Given this list of marker genes G6PC3, TCN2, SKIC3, SPRED2, PTPRC, FAT4, TPP2, PTEN, RMRP (NCBI Gene Id 6023), ACP5, UHRF1, TERC, TTC7A, TTI2 (TELO2 interacting protein 2), TOM1, CORO1A, RAC2, STING1, LBR, WAS, CD3D, CD81, DEF6, FCHO1, BCL11B, GATA2, TNFAIP3, C1GALT1C1, CASP10, GFI1, GALE, TP53, TFR2, AK2, JAK3, ADAMTS3, RRAS2 (NCBI Gene Id 22800), MYSM1, DCLRE1C, IRF2BP2, ICOS, SAMD9, NCAPG2 (non-SMC condensin II complex subunit G2), FBXL4, CTLA4, GTF2H5, IL2RG, CHD7, CDCA7, USP48, STAT1, IL7R, LAT, CTNNBL1, DNMT3B, NAE1, SLC19A1, SGPL1, HELLS, ADA, RAP1B, CCBE1, MSN, TCIRG1, TINF2, RAG2, RAG1, PIK3CG, CLPB, CDH23, UNC119, IL6ST, PIK3R1, NR3C1, EXTL3, ADA2, FASLG, ATRX, CTPS1, NFKB2, CYBC1, IRAK1, IL36RN, PSMB4, RPA1, ELANE, XRCC4, PSMB9, STAT2 (NCBI Gene Id 6773), ZBTB24, TNFSF12, AP1S3, CR2, ORAI1, TNFRSF13B, CD3E, PNP, SPP1, STAT4, CXCR4, FAS, USP8, ICOSLG, SKIC2, PGM3, IL7, TLR7, TERT, TNFRSF13C, SAT1, ATM, IFIH1, PRIM1, GINS1, NHEJ1, BRAF, CD19, EPG5, NFKB1, NAF1, MTHFD1, CD247, PI4KA, SMARCAL1, WIPF1, SRP19, MDM4, MS4A1, STK4, here is a description of the gene set: studied in species Homo sapiens Human Gene Set: HP_DECREASED_TOTAL_LYMPHOCYTE_COUNT Decreased total lymphocyte count A reduced number of lymphocytes in the blood.